Given this list of marker genes CYP27B1, TPK1, SLC25A19, PSAT1, CYP2R1, PNPO, PDXK, SLC19A3, CYP27A1, TNF, IFNG, THTPA (NCBI Gene Id 79178), PLTP, SLC19A2, UBIAD1, GFI1, SNAI1, RFK, CYP3A4, BCO1, SNAI2, NFKB1, CYP24A1, here is a description of the gene set: species: Homo sapiens The chemical reactions and pathways resulting in the formation of a vitamin, one of a number of unrelated organic substances that occur in many foods in small amounts and that are necessary in trace amounts for the normal metabolic functioning of the body. Human Gene Set: GOBP_VITAMIN_BIOSYNTHETIC_PROCESS